The following is a description of a gene set: Human Gene Set: GOBP_STEROID_HORMONE_BIOSYNTHETIC_PROCESS species: Homo sapiens The chemical reactions and pathways resulting in the formation of any steroid hormone, naturally occurring substances secreted by specialized cells that affects the metabolism or behavior of other cells possessing functional receptors for the hormone., and this is the list of marker genes: CYP19A1, SERPINA6, SCP2, BMP5, HSD17B7, EGR1, CYP11B1, DKK3, HSD17B6, HSD17B8, CYP11B2, DAB2 (DAB adaptor protein 2), LHB, STARD3, REST, HSD17B1 (hydroxysteroid 17-beta dehydrogenase 1), ATP1A1, BMP2, NR5A2, SRD5A2, CYP21A2, H6PD, HSD3B1, WNT4, CLCN2, AKR1B1, ADM, HSD17B3, SRD5A3, NR3C1, TSPO, HSD17B11, CYP17A1, SRD5A1, BMP6, CYP11A1, DHRS11, CRH, HSD3B2, HSD17B12, HSD17B2, DGKQ, RDH8, AKR1B15, CACNA1H, MED1, FSHB (follicle stimulating hormone subunit beta)